The following is a description of a gene set: part of: Amine ligand-binding receptors Reactome Pathway: Adrenoceptors studied in species Homo sapiens The adrenoceptors (adrenergic receptors) are targets for the catecholamines adrenaline (epinephrine) and noradrenaline (norepinephrine). These receptors are widespread in the body and binding of catecholamines produces a sympathetic response ('flight-or-fight response') resulting in increased heart rate, pupil dilation and energy mobilization amongst other responses. There are three major types of adrenoceptor, alpha1, alpha2 and beta. Each type is thought to have three subtypes; alpha1 (1A,1B,1D), alpha2 (2A,2B,2C) and beta (1,2,3) (Bylund DB et al, 1994)., and this is the list of marker genes: ADRA2C, ADRA2B, ADRB3, ADRA2A, ADRB2, ADRA1D, ADRA1A, ADRA1B, ADRB1